Given this list of marker genes PACC1, GSN, LRRC42, EGR3, BLTP1, LARP4B, GZMA, WDR12, NRM, RPL31 (NCBI Gene Id 6160), DDIT3, PPP1R3B, BCL9, PI4KA, G0S2, ADCY6, DAPK1, CBX2, DAPL1, ZBP1, SRSF12, TMEM108, ACVRL1, NDRG1, CHD3, FRY, ARID3B, TRPM7, USP40, NEDD4, ADH1C, CD47, CCR9, PODXL, KCNA2, SMC4, ZYG11B, PDLIM1 (NCBI Gene Id 9124), IFIT3 (interferon induced protein with tetratricopeptide repeats 3), IGF2BP2, ADGRG3, YJU2B, KMT2D, CERS6, KIAA0040, NDRG2, IGFBP4, TET1, EIF4E3, CYP2D6, GOLGA3, CHDH, USP34 (ubiquitin specific peptidase 34), SGK3, CACNA1D, SORCS2, PMEPA1, BACE1, CD8A, TRAM2, GPRC5B, LGMN, BASP1, MEF2A (myocyte enhancer factor 2A), ITM2A, TMEM35A, SLC16A10, RALGPS2, SHE, RASL11B, DNAI4, UBN1, PTPN2, PTGIR, PAK1, CDC42EP4, STT3B, PURB, CUL3, IMPDH1, ZNF605, DDX49, MMP11, GATA1, RNF213, STMN1, RAB3IP, ALS2CL, CRIPTO, CYTIP, WDR46 (WD repeat domain 46), MYO6, LZTFL1, ART4, DNMT3A, SMC6, RASGRP2, COX7A2, TIPARP, CCDC30, TRIM59, MINDY2, KIF20A, AMIGO2, MMP15, VANGL2, BEND5, GEN1, PCED1B, BNIP3L, GABRR2, BRDT, HECTD2, TET3, GUCD1, DMAC1, GGPS1, AMPD1, IL17RB, VASH1, EPB41L2, NLRC3, FOXN3, SOX4, MARCKS, SELL, BACH2, ITGB3 (integrin subunit beta 3), UBTD2, IGSF23, DNTT, DYRK2, FRMD6, CACNA2D2, CD81, PDLIM4, TRIM56, MTSS1, XKRX, MYL4, BBS9, TMIE, FRMD4A, OSBPL8, AGO2, BTK, TUT4, CD7, SEMA4G, AMPD3, GPR18, PALS1, CHML, ZNF281, BCL3, ZBTB34, TREML2, ADA, GTF2IRD1, H3C14, SMO, EMID1, CALCRL, DGKD, PADI3, TUBB2A, SLC27A4, IL31RA, DENND6A, ECM1, TKTL1, TNIK, LEF1, TMCC3, SMCHD1, SUSD1, GDPD3, DLEU7, NFKBID, TNS1, SAMD8, ZCCHC12, CD163, NCKAP5L, ZDHHC14, GALNT10 (polypeptide N-acetylgalactosaminyltransferase 10, NCBI Gene Id 79615), UBE3A, IKZF3, SLC16A5, FOXO1, CREB1, MX1, ATP1B1 (NCBI Gene Id 481), MYL6B, GK5, TTC3, IFT80, IFNGR2, CA2, here is a description of the gene set: studied in species Homo sapiens Human Gene Set: GSE39916_B_CELL_SPLEEN_VS_PLASMA_CELL_BONE_MARROW_UP from publication Benson MJ, Aijö T, Chang X, Gagnon J, Pape UJ, Anantharaman V, Aravind L, Pursiheimo JP, Oberdoerffer S, Liu XS, Lahesmaa R, Lähdesmäki H, Rao A (PMID 22991471) CD138+ B220- plasma cells were sorted from bone marrow and B220+ CD23+ mature follicular B cells were sorted from the spleens. Plasma cells were sorted from C57BL/6 mice 7 days after boosting with antigen, with mice first primed with an i.p. injection of KLH/IFA followed by boost at day 21 with KLH/PBS i.p. Mature B cells were sorted from antigen-naïve C57BL/6 mice. We compared expression profiles of plasma cells and mature B cells to identify differentially expressed transcripts. Genes up-regulated in spleen B lymphocytes versus bone marrow plasma cells.